Given this list of marker genes JPH4, NPNT, POU4F2 (POU class 4 homeobox 2), MLH3, TFAP2B, R3HDM2, PAX6, GNAZ, IFFO1, GPM6B, RORA, LTBP1, DIXDC1, LRRTM3, PNOC (prepronociceptin), CHD6, TCF21, USP2, NECTIN1, MECOM, PTCHD4, HSD11B1, GOLM2, ATP2A3, PCYT1B, DNAJB9, ESRRG, NFIA, TRERF1 (transcriptional regulating factor 1), MFSD14B, C12orf54, C2CD2L, PRDM12, YRDC, C6orf62, ZNF407, ELMO3, ANGEL1, KLF3, SLITRK2, ZC3H6, ATF7, NOG, IGFBP7, POLG, FRAS1, TOB1, MNAT1, MCUB, SERPINI2, OTULINL, SEMA3A, ARF6, CRIM1, SATB2, AP2M1, CSMD3, ZNF516-DT, HAS2, SCUBE3, GUCY2C, AAMP, CDH20, FCHSD2, DCDC1, DMD, HOXA10, PHACTR3, TTC3, MPPED2, KLHL1, BMPR2, EFEMP1, FOXN3, SSH2, TRIB2 (tribbles pseudokinase 2), NECAB3, MAP2 (microtubule associated protein 2), HOXC12, ORC4, NFIB, PDZD2, LMO3, NRAS, SLC26A7, CRYGB, XPOT, KIRREL3, B3GLCT, TMEM229B, BMI1, ARPP21, POU3F4, ROGDI, PNKD, TXLNG, GSTO2, DLX2, SPTLC2, PPARGC1A, GRIN2B, LRP1B, GOLGA1, SYT6, DND1, ACKR3, GARRE1, ENSG00000255537, KIRREL3-AS3, IGSF21, ADAM23, HDAC9, GHR, UGT1A6 (NCBI Gene Id 54578), MYOCD, CADM1, SAR1B, ANP32D, NPTX2, CCL2, LEMD1, BMAL1, EDN1, ECT2, SMARCD1, FGF7, SATB1, TFEC, CDK6, ZBTB18, MAF, CALHM5, ID1, C1orf87, ADAMTSL1, CTXN1, NEIL3 (NCBI Gene Id 55247), ZC3H14 (NCBI Gene Id 79882), PAFAH1B1, PDE4D, ATP2B4, DCHS1, CAST, SLC34A3, SERINC5, ZFHX4, PTPRO (NCBI Gene Id 5800), NECTIN3, SAMTOR, NRXN1, IL20 (interleukin 20), NRF1, TBX5, SRSF7, ATF3, HESX1, PHF6, ARL4C, CACNA1C, TASP1, KRT84, MXI1, COL10A1, PDE4B, NR2F1, C1orf122, GPR107, NFIX, MRPL47, DMC1, ERG, FOXP1, AMBN, PSMA8, SEPTIN4, ADGRB3, HTR1F, SARAF, OLR1, PHF20L1, NKX2-1, SIPA1 (NCBI Gene Id 6494), PRDM1, SLCO1A2, LEMD2, RARB, SLC39A14, LIFR, MBD6, CHD2, TUBA1A, PURA, PPM1B, HPSE2, CALCOCO1, CCDC91, UCHL3, DNAH12, IL2RA, ACVR1C, HOXA7, RAB5B, NDUFB5, TMEM156, CDK14, CD180, PDZD9, CDH9, ANAPC11, NEO1, FAM117A (NCBI Gene Id 81558), SDHC, UBE2E1, DYNC1LI1, AMELX, BCL6, SOBP, HOXA9, KLF3-AS1, COLCA1, RBM39, HOXC4, NOL4L (NCBI Gene Id 63890), SOX2, FEZ1, ATRNL1, LINC01164, ARSG, FGF13, TCF4, TRIM2, RORB, IPO4, CDH10, PBX1, INPP4B, FSIP2, TEAD1, PTHLH, BCL11A, UTRN, PYGO2, ZNF423, here is a description of the gene set: Genes having at least one occurrence of the motif AYMATAATATTTKN in the regions spanning 4 kb centered on their transcription starting sites. This matches the FOXJ2 transcription factor binding site V$FOXJ2_02 (v7.4 TRANSFAC). species: Homo sapiens Human Gene Set: FOXJ2_02